The following is a description of a gene set: Decreased mean corpuscular volume A reduction from normal of the mean corpuscular volume, or mean cell volume (MCV) of red blood cells (usually defined as an MCV below 80 femtoliters). studied in species Homo sapiens Human Gene Set: HP_DECREASED_MEAN_CORPUSCULAR_VOLUME, and this is the list of marker genes: SLC4A1, GTF2E2, GLRX5, SLC25A38, TRNT1 (tRNA nucleotidyl transferase 1), STEAP3, SLC11A2, TMPRSS6, LPIN2, HBB, NHLRC2, SPTB